The following is a description of a gene set: Any process that modulates the frequency, rate or extent of adenylate cyclase activity. studied in species Homo sapiens Human Gene Set: GOBP_REGULATION_OF_ADENYLATE_CYCLASE_ACTIVITY, and this is the list of marker genes: GNAI3, GNAI2, ADORA2B, CACNA1C, EDNRA, ORAI1, GLP1R, GALR1, EDNRB, AKAP5, STIM1, CACNA1D, DRD5, GNAS, CAP2, GRM2, P2RY11, CRHR1, GRM3, GABBR2, ADCYAP1, LTB4R2, AVPR2, ADGRV1, ADORA3, CALCA, GIPR, CCR2, TMIGD3, CAP1, ACR